Given this list of marker genes UPK3B, SPEF1, HSPA1A, HABP2, CDKN2C, LINC02532, NCALD, TONSL, TM4SF4, ENHO, SCARA5, OLFML3, VIL1, ADH6, PRR15L, NRGN, FEN1, TK1, BCAS1, KCNK5, NHERF4, HLA-DMB, HPDL, TXNDC5, RNF43, SLC26A9, RADIL, RIBC2, DPEP1, MCM5, EPHB3, ANKS4B, ELN, SERPINA6, DHCR24, SDF2L1, PDF, DIO2, LINC01559, FAM111B, C9orf152, SP9, PACSIN1, SPDEF, PEG10, KLHDC7A, RASD1, PRODH2, H2AX, MXD3, HNF1A-AS1, MYO1A, CCND3, ADAT3, NR4A1, FASN, FAM222A, SLC25A10 (solute carrier family 25 member 10), KRT4, NEB, CBLN2, RECQL4, INSL4, SFRP4, SYNGR4, KRT8, LRRC45, DACT2, FGFR4, PRR15, H19, MCM10, GPX2, CNTNAP2, DDC, SOX2, PIK3R3, here is a description of the gene set: Genes down-regulated in SARS-CoV-2 infection (A549 cells, MOI: 2, 24hpi) species: Homo sapiens Human Gene Set: BLANCO_MELO_COVID19_SARS_COV_2_INFECTION_A594_CELLS_DN Analysis of the transcriptional response to SARS-CoV-2 compared with other respiratory viruses, including MERS-CoV, SARS-CoV-1 (SARS), human parainfluenza virus 3 (HPIV3), respiratory syncytial virus (RSV), and IAV. from publication Blanco-Melo D, Nilsson-Payant BE, Liu WC, Uhl S, Hoagland D, Møller R, Jordan TX, Oishi K, Panis M, Sachs D, Wang TT, Schwartz RE, Lim JK, Albrecht RA, tenOever BR (PMID 32416070)